Given this list of marker genes LRIG1, LRIG3, SLC44A4, TTC39C, BLOC1S5, here is a description of the gene set: Human Gene Set: GOBP_OTOLITH_MORPHOGENESIS species: Homo sapiens The process in which the anatomical structures of an otolith are generated and organized.